The following is a description of a gene set: species: Homo sapiens The side (leaflet) of the endosome membrane that faces the cytoplasm. Human Gene Set: GOCC_CYTOPLASMIC_SIDE_OF_ENDOSOME_MEMBRANE, and this is the list of marker genes: RAB21, CDIP1, SNX5, LITAF, MICALL1, LITAFD, RAB5A